The following is a description of a gene set: The process in which neuroepithelial cells of the neural tube give rise to radial glial cells, specialized bipotential progenitors cells of the brain. Differentiation includes the processes involved in commitment of a cell to a specific fate. Mouse Gene Set: GOBP_RADIAL_GLIAL_CELL_DIFFERENTIATION species: Mus musculus, and this is the list of marker genes: Lamc3, Metrn, Miat, Stat3, Reln, Lef1, Gli3, Mettl3, Gpr157, Hes1, Nfix (NCBI Gene Id 18032), Lamb2, Lrp6, Emx1, Ccdc85c, Mettl14, Fgf10, Rhoa, Afdn, Hes5, Gap43, Cdh2, Casz1